The following is a description of a gene set: from publication Gryder BE, Yohe ME, Chou HC, Zhang X, Marques J, Wachtel M, Schaefer B, Sen N, Song Y, Gualtieri A, Pomella S, Rota R, Cleveland A, Wen X, Sindiri S, Wei JS, Barr FG, Das S, Andresson T, Guha R, Lal-Nag M, Ferrer M, Shern JF, Zhao K, Thomas CJ, Khan J (PMID 28446439) While previous studies have attempted to identify PAX3-FOXO1 target genes, these were based either on changes in gene expression or proximity to PAX3-FOXO1 in a single cell line with no consideration of expression or chromatin context. By gene expression many targets could be falsely identified which were in fact indirect, and 336 (31%) of the nearby genes previously reported to be direct targets were not expressed, while others may not be physically interacting because of barriers in 3D chromatin space. We therefore identified high-confidence PAX3-FOXO1 target genes by a series of criteria: first, using only PAX3-FOXO1 bound to enhancers recurrent in cell lines and tumors. Secondly, we only selected expressed genes, as PAX3-FOXO1 was not found in repressive chromatin. Third, we excluded nearby expressed genes if they were not found within the same topologically associated domain (TAD) as the PAX3-FOXO1 bound enhancer. Fourth, we also called out the maximally expressed gene within each TAD harboring PAX3-FOXO1. This approach removed 435 nearby but not expressed genes, and 78 expressed but out of TAD bounds. We found 1010 high-confidence targets, 678 of which were novel, and 439 were significantly reduced by shRNA knockdown of PAX3-FOXO1 for 48 hours. Novel targets include 24 oncogenes, 14 pan-cancer upregulated genes, 53 transcription factors, and 7 imprinted genes, many of which were rapidly decommissioned upon depletion of P3F (both reduced RNA-seq and H3K27ac at their enhancers. Human Gene Set: GRYDER_PAX3FOXO1_ENHANCERS_IN_TADS studied in species Homo sapiens Expressed genes (FPKM>1) associated with high-confidence PAX3-FOXO1 sites with enhancers in primary tumors and cell lines, restricted to those within topological domain boundaries, and this is the list of marker genes: WDFY3, WDR11, SCARB1, TLE1, ARPC2, PFN2 (profilin 2), PODXL2 (podocalyxin like 2), PKP1, SNRPC, PSMD8, RNF149, EEF2K, TFAP2B, PEMT, PRCP (NCBI Gene Id 5547), NOG, SDE2, RAE1, TM2D3, CTNNBL1, CCNY, ARK2N, PLXNA2, ANK2, FUBP1, ARHGEF3, NFYA, SLIRP, ANTXR2, AOPEP, C5orf15, ANLN, CRPPA, NAV1, ZIM2, FAM110B, NAA20, IGFBPL1, ACBD6, VAX2, SOCS3, DDB1, ATOH8, ATP8B4, SLC7A1, THEMIS2, SELENON, STX8, MSH6, PNRC2, PARD3, DAPK1, LEPROTL1, CUX1, SDK1, PSD3, BMERB1, SRSF5, PRMT3, HS1BP3, TOM1, VTI1A, TGOLN2, COL4A2, COX7A2L, ZNG1A, CHST15, SRP9, VLDLR, PPCDC, GNL3L, TMEM131L, EMC1, MCM3, ZNF664, CADM2, FHIP2A, BCL11A, SARS1, MSI2, DMRT2, SERPINE2, MCFD2, DPYSL3, KANK2, CLASP1, TOR1AIP2, WSCD1, NPM3, HMGXB4, TRIO, CSE1L, FAM89A, ZCCHC9, UCHL1, SHISA2, GNA13, TNFRSF19, ESYT2, POLR2J, EFNA5, GNG12, PRKAR1A, PODXL, RASSF4, C3orf70, STIM2 (NCBI Gene Id 57620), NDUFA12, TRIM32, BCL2, ECHS1, ARMC1, NCAPG2, RGMA, YAE1, CCZ1B, CA11, SEC61B, TAB2, RNF181, CEP97, RBMS1, LRPAP1, DCTD, CBR1, CALCRL, MRPL20, TRAP1, BBIP1, CHCHD3, ZNF488, TTLL7, ASTN2, JARID2, PHF12, MAGI1, MTA3, SDK2, PAX3, CHST11, TOP1, ASS1, BRCA2, SETD7, NFIA, SFMBT2, SLC38A1, SRSF10, PGM1, SUMF1, MCM2, SSB, TPP2 (tripeptidyl peptidase 2), RPL23A, RBM20, ATP5MJ, TNNT2, ARHGEF10, ANKS6, NSDHL (NAD(P) dependent steroid dehydrogenase-like, NCBI Gene Id 50814), HERC2, NR3C1, MSRB2 (methionine sulfoxide reductase B2), AEBP2, PABIR2, FOXK1 (forkhead box K1), ZMIZ1, NHP2, SMARCB1, KCNMA1, DNTTIP2, OLIG2, TMEM165, REPIN1, CHST8 (carbohydrate sulfotransferase 8), NFE2L2, PNO1, SPOCK3, KIAA1614, ZNF75D, RFC3, MYO18B, TCF20, CDK6, TEX261, ACVR1, PARK7, MAN2A1, SOD1, AQR, SKP2, LOXL2, LMO4, BRD8, TLE5, SASH1, MSH3, BTD, NCS1, HDAC5, IMMT, FAM217B, GNAS, SGMS1, ETAA1, ATF7IP, CUL3, COL18A1, MEDAG, OAT, CDK14, DAZAP2, BCHE, NRN1, PRUNE2, THAP1, NUF2, DARS1, VANGL2 (VANGL planar cell polarity protein 2), TOX3, OBSL1, PRDM12, DNAJC10, BCAR3, EYA4, ARGLU1, CHD7, SNN, MIF, SNX9, FIP1L1, PARP1, SETBP1, PTPRD, SSH2, ARHGAP15, HDHD5, PFDN4, ZFP36L1, SDC3, ATF3, CEP85, ERLIN2, RSL1D1, SRD5A3, SLC46A3, RRP15 (ribosomal RNA processing 15 homolog), ZXDB, ASB7, RNF114, MLH1, HSPG2, NCOA1, EXOSC2, TMEM123, PIGC, IGF2, KLF5, ACTR8, IRX1, AP1B1, VRK1, APBB2, SDC2, NLGN1, EWSR1, TAGLN3, LARS2, MN1, ALOX5AP, IDH3A, USP1, NSMCE1, ZNF568, TBC1D2B, KCNN3, CDH4, DLG5, CDC42EP3, SOX8 (NCBI Gene Id 30812, SRY-box transcription factor 8), ELMO1, BCOR, TSPAN9, FAU, BAIAP2, CREBBP, KIAA1217, CAND1, PSMD6, FANCF (FA complementation group F), SMC5, GPHN, NHEJ1, ARL14EP, SYNDIG1, PKNOX2, SENP2, MEGF10, SELENOW, UGCG (UDP-glucose ceramide glucosyltransferase), MAPK6, PFDN2, ACYP1, POLR2D, ITGB1, TRIQK, C11orf58, PARM1, ZNF331, GALNT11, RXRG, CGRRF1, CEBPZ, MAF, TLE3, FGGY (FGGY carbohydrate kinase domain containing), NOC3L, CEP112, ATE1, HSPA4, PGBD5, NCAM1, SLC2A10, SF3B2, MYO9B, EFHD2, GINS2, RIMKLB, MTREX, RNF216, SFXN1, MAN1A2, WEE1, ASB13, NCKAP1, NAT10, PLCE1, ERGIC1, FBXO21, EXT2, SETX, FARSB, MCC, POLR1F, GIT2, HPCAL1, ACOX3, MDFI (MyoD family inhibitor), SRSF6, C2orf69, POMP, ECI2, ARHGAP26, HMGCR, CNOT2, FGFR2 (NCBI Gene Id 2263), PCBD1, FBXO7, ZNF420, KRCC1, FUT10, PROX1, ECT2, RPS6KC1, NDUFS4, YWHAZ, ATP6V1B2, MRPL13, GPC3, PCM1, DCAF5, MEST, PCSK6, ATP9B, SSU72 (SSU72 homolog, RNA polymerase II CTD phosphatase), CTR9, FLRT2, FAT1, AUTS2, POMT2, DNAJB6, ZNF330, EYA2, TIMM9, PSMB4, B4GALNT3, FAM229B, STMP1, IRS1, SRGAP2C, COPS8, ITPKB, HS6ST2, SDC1, PAFAH1B3, NUDC, WNK1, MYCN, HMGN2, ZNF217, RFC5, RRP1B, GNB5, BMP5, EXOSC7, TXNRD1, HELB, COX11, SLC38A10, ZNF622, MACROH2A1, PTGFRN, MAP3K2, FAF1, WSB2, FGF8, PLAC1, MRS2, OS9 (NCBI Gene Id 10956), NRG1, POLR1D, TCF7L2, MAP2K5, CDC5L, MYH9, RNF145, TFPI, TTC12, COX4I1 (NCBI Gene Id 1327), PALD1, SLC4A2, MRPL23, UQCC4, NDUFAB1, XPO7, CITED2, HNRNPA3, SHC1 (SHC adaptor protein 1), ZNF77, FAM151B, CCDC3, DIS3L (DIS3 like exosome 3'-5' exoribonuclease), COPA, FGFR4, DHX32, ZFYVE16, ABCD3, RBFOX1, GDI2, RGPD4, ITPR1, YIPF5, RBL2, CDCA2 (cell division cycle associated 2), GXYLT2, KCNS3, POR, CD9, SBF2, GNPDA1, COPS3, SPATS2L, SLC38A9, CHSY1 (NCBI Gene Id 22856), PCCB, TBC1D1, ST6GAL2, ITGA1, OLFML2B, ACTR5, MAT2A, TSHZ3 (teashirt zinc finger homeobox 3), RNF11, SNX29, REXO2, ACTR3C, WDR27, DDOST, SLC7A2, NOP10, RAPH1, TNFAIP3, SPATS2, IL1RAP, STX16, NR2F2, DUSP12, TPST1, GDAP1, ACTG1, ELP1, MON2, TBCD, PEG3, HAUS1, ATP2A2, HSBP1, PRRC2B, PON2 (paraoxonase 2), PLXNA1, PEG10, SERP1, MARCKS, ZFAND3, EYA1, UQCRC2 (ubiquinol-cytochrome c reductase core protein 2), SPRY1, PXDN, CD81, PBX1, CTDSP2, COX6C, C5orf22, METTL13, ZC3H13, DPY19L3, NCOR2, MEIS1, TNFRSF21, ITGB8, LIMD1 (LIM domain containing 1), SIPA1L1, QKI (NCBI Gene Id 9444), PKN2, ZDHHC21, ACTB, RGS3, PRKRIP1, BTAF1 (NCBI Gene Id 9044), UBE2E2 (ubiquitin conjugating enzyme E2 E2), UQCR10, ARL4C, ZNF264, ATP6V1D, MNAT1, GTF3A, ALDH1A3, VIM, TSC22D2, INPP4B, CASP9, ERRFI1, ADAM10, ATP1B1, APP, TRAM2, DCP2, FOXO1, ARID1A, DDX1, SLC38A6, RAD51B, DOCK10, MYO9A, WARS1, SLC16A2, SNTB1, RPF2, SF3A3, PSIP1, SLC25A26, SACS, MYC, SKA2, FAM83D, RAD51C, TNPO1, SCFD2, DPF1, STAG1, IL4R, ACSL3, F11R, FRG1, SP3, GRN, C10orf71, TBCA, COL4A1, SERTAD2, MEX3B, RANBP17, CABLES1, CDYL, TTI1, GNG11 (NCBI Gene Id 2791), MFSD2A, TANK, ETV5, DYRK2, CASQ2, PITPNB, CASK, HACL1, MET, PLAAT1, VGLL3, TBX15, GALNT17, FCRLA, RASA3, RBM38, TUT7, WNT5B (Wnt family member 5B), SUMO2, SORCS1, ADAM19, ZNF644, SEMA6A, SLC38A2, ENAH, ACTC1, THSD4, MYOD1, VASH2, ATF6, R3HDM2, OAZ1, PEBP1, NOS1, VIPR2, PDE4DIP, MTPAP, SATB2, STXBP5, CGNL1, MIS18A, RBBP8, STC1, CEP128, INVS, XRN1, GNPAT, NANS, VPS4B, AFAP1L2, FOXF1, FOXP1, TNS3, ZNF57, NOLC1, PKM, PACS1, CDC7, DEAF1, ATPSCKMT, TMEM177, RAP2C, LRRFIP1, TSPAN3, PTS, ERI1, CDC123, WDR1 (WD repeat domain 1), ACAD8, LMNB1, ANKRD17, SH3BGR, PLCG1, CHD6, INTS6, NUP62, RRM2B, CD82, AGAP1, ATRN, VDAC1, JPT2, ACLY, CSRNP2, APPL1, ADCY9, ATAD2B, NEDD1, FGF7, NRP2, POGZ, EIF3A, TSPAN7, STC2, FAM81A, PPP4R2, SULF2, CDH13, LDLRAD3, MIPEP, APMAP, GLRX5, ASCC3, ZNF483, NFIB, LRIG3, SOX6, ST6GALNAC3, STARD13, RBPJ, TEX10, RAPGEF1, RHOQ, ENC1, LAPTM4A, UBE2G2, POLE3, LYPLAL1, NDUFS1, SNRPD3, ZNF804A, INKA2, CELF2, SMARCA4, UBAC2, ATP1A3, SYNE3, KIF5B, CHD2, NXT1, FARS2, TVP23C, C1GALT1, SMPDL3A, GOPC, CCNC, MPHOSPH9 (M-phase phosphoprotein 9), FASTKD2, PITX2, CEP85L, SNRNP40, FAM199X, CCT5, TTC28 (tetratricopeptide repeat domain 28), ARHGAP29, ITSN2, TRA2B, UBL7, DNM3, SMARCA2, ATP6V1E1, NOSIP, KBTBD8, KHDRBS3, MED9 (NCBI Gene Id 55090), ADO, CAV2, ANKS1A, SHB (SH2 domain containing adaptor protein B), GNA12, BCAT1, DHX9, VMA21, HUNK, WWOX, ADAMTS15, TMCC3, SFT2D2, COA6, GADD45A, TENT5A (terminal nucleotidyltransferase 5A), STX11, FHIP1B, PMP22, SAMD4A, DCLK1, FSCN1, UBE2J1, ARHGAP12, PIPOX, SNX19, TNFRSF10B, ATXN1, VPS13B, PARN, ZW10, ELAVL2, GNAZ, PREX1, OSBPL2, DPH5, FRMD8, ZNF18, GOLGA7, ZZEF1, PPIF, RMI1, AP5M1, SLX9, LMCD1, PPIL4, MAPK8, GALNT2, MBTPS2, GGA2, WDR43, STXBP6, CCND2, PDZRN3, RAD23B, PGF, GLUL, GART, TTK (TTK protein kinase), KANK1, LNPK, MSX2, MYH14, ADAMTS1, DROSHA, LRRFIP2, PHF6, COBL, IFT81, ERICH1, AGPAT5, RNGTT, NUP205, IGF2BP2, CCNB2, SPICE1 (NCBI Gene Id 152185), STK24, COX5A, KLHL29, TNKS2, FAR2, GMPR, GBF1, ALG13, DUSP1, NELL1 (NCBI Gene Id 4745), DEK, TMBIM4, SMS, ETNK1, USP15, POFUT2, SEL1L3, UBE2G1, SVIL, CAPRIN1, SPIN2B, GRB10, TM2D1, N4BP2L2, SPRY4, C1orf43, MRTO4, RCN1, PTAR1, UBR3, GPR89B, AFAP1, N4BP3, TBL1XR1 (TBL1X/Y related 1), JAKMIP2, GSE1, SPSB4, TRIM45, NACA, PGRMC2, PHLDB2 (pleckstrin homology like domain family B member 2), CDCA7, ATP5IF1, LZTS1, CAP1, CNTLN, IL17RD, WIPI2, EPHB2, DAAM1, PRKG1, SPATA13, CAAP1, SLC16A10, EZR, CSRP1, APLF, SOX4, MAD1L1, ABRACL, LRIG1, PTTG1IP, CDK2AP1, C1orf131, ELAPOR2, FOXN2, FAM174A, GPR107, SUDS3, LRRC10B, RCHY1 (NCBI Gene Id 29027, ring finger and CHY zinc finger domain containing 1), PDGFC, ERH, PTCD2, COMMD10, PTPN12, NPM1, MIOS, ZEB2, PPP1R3B, NAPG, KCTD2, RRAGC, PRKX, HP1BP3, BABAM1, CEBPG, SETMAR, TENM3, DIS3, CLCN5, KCNMB4, COX16, MED13L, MOCS2, CDON (NCBI Gene Id 50937), SF3B5, HNRNPAB, RALA, FZD8, DDX10, FYN, TCF7L1, GLO1, EID1, SPDL1, HNRNPK, MDH2, STAT3, NUP160, FAM136A, IER5, FTO, NAV2, GAS1, ADAMTS14, RGMB, PINX1, HELLS, CSTF2T, OPA1, MYLIP, SIK1, SETD3, VDAC3, RUNX1, ST3GAL4 (ST3 beta-galactoside alpha-2,3-sialyltransferase 4), ACVR2A, CYRIA, ODC1, TPX2, NDUFA6, ALK, HNRNPA0, EIF3B (NCBI Gene Id 8662), ABL1, STOML1, M6PR, PSMB6, WDR45B, NOTCH2, HSPH1, TRIM44, SYTL3, EXTL3, FBXL7 (NCBI Gene Id 23194), KANK4, ILK, MAGED2, TCF12, RRAGA, CACUL1, DTD1, MEIS2, PID1, INPP5A, CPA5, MAN1C1, LARP1B, RERE, BFAR, MYO18A, TOP2A, HECTD2, LAMB3 (laminin subunit beta 3), VAPA, DBT, MAP4K4, DICER1 (dicer 1, ribonuclease III), NDUFS3, RGS17, ANKRD13A (NCBI Gene Id 88455), ZNF71, PARP4 (NCBI Gene Id 221181), ZDHHC6, KREMEN1, NSUN6, NKAIN1 (sodium/potassium transporting ATPase interacting 1), DUSP6, SUCLG2, PDHB (pyruvate dehydrogenase E1 subunit beta), MRPS18C (NCBI Gene Id 51023), TUBA4A, SLC24A3, PPM1H, ARL8B, BCCIP, CLINT1, PGS1, KLF9, LIMCH1, VSTM4